Given this list of marker genes RPL8, CLU, TUBA4A, DDR1, TRAPPC5 (NCBI Gene Id 126003), MT1H, SOCS3 (NCBI Gene Id 9021), RPL10A, RPLP1, NDUFA6, MT1E, MT1G, NDUFAF8, DUSP7 (dual specificity phosphatase 7), RPS20, TMSB10, SEC61G, SERPINA3, BBLN, NACA, UQCR11, RPL15, RPS26, PERP, RPL7A, RPS19, RPS7, ACTG1, CNPPD1, RPLP2, RPS13, SNHG6, RALA, RPS18, RPS16, EEF1D, RPS10, EPS8L2, NFIB, F11R, RPL35A, RPL39, S100A2, UBA52, LAMB3, KRT14, LAMTOR2, SOX4, GNPTAB, TIMM8B, UBL5 (ubiquitin like 5), RPS25 (ribosomal protein S25), WFS1, RC3H2, EHD4, PET100, HINT1, KARS1, MARS1, COX4I1, EIF3K, RPS2, RPL23A, CEBPD, PTMA, RPL24, DLL1, OXLD1, DYNLL1, BAG3, PPIA, MGP, RPL41, FTH1P5, KRT17, RPS28, CLTB, GAPDH, ATP5MG, PKP1, RPS29, SMARCA4, NDUFS5, CSTB, TMA7, RPL18A, PRDX2, KRT8, MT1F, RPL7AP36, TXN, NDUFB2, STK35, FAU, ATP5F1E, GUCD1, RPL27A, RPS3, CNP (2',3'-cyclic nucleotide 3' phosphodiesterase), TUBB2A, UQCRB, EDF1, DDX24, RPL22, RPL13, RBIS, AK1, NFE2L2, TBCA, TALDO1, RPL13A, MANBA, NDUFA11, RPS12, HINT3, COX7A2, KRT6B (NCBI Gene Id 3893), DDT, NDP, NOP53, RPL28, ABHD6, COX6C, RPSA, TUBB4B, MT2A, CDC42SE2, AKR1C1, IL4R, RPS14, RPS19BP1, RPL36AL, ATP5ME, MT1X, APOE, TUBB2B, KRT16, TMX2, here is a description of the gene set: Human Gene Set: PECE_MAMMARY_STEM_CELL_UP from publication Pece S, Tosoni D, Confalonieri S, Mazzarol G, Vecchi M, Ronzoni S, Bernard L, Viale G, Pelicci PG, Di Fiore PP (PMID 20074520) The '3/3 signature': genes consistently up-regulated in all three pools of normal mammary stem cells (defined by their ability to retain the dye PKH26). Pathways that govern stem cell (SC) function are often subverted in cancer. Here, we report the isolation to near purity of human normal mammary SCs (hNMSCs), from cultured mammospheres, on the basis of their ability to retain the lipophilic dye PKH26 as a consequence of their quiescent nature. PKH26-positive cells possess all the characteristics of hNMSCs. The transcriptional profile of PKH26-positive cells (hNMSC signature) was able to predict biological and molecular features of breast cancers. By using markers of the hNMSC signature, we prospectively isolated SCs from the normal gland and from breast tumors. Poorly differentiated (G3) cancers displayed higher content of prospectively isolated cancer SCs (CSCs) than did well-differentiated (G1) cancers. By comparing G3 and G1 tumors in xenotransplantation experiments, we directly demonstrated that G3s are enriched in CSCs. Our data support the notion that the heterogeneous phenotypical and molecular traits of human breast cancers are a function of their CSC content. studied in species Homo sapiens